Given this list of marker genes VCP, TREM2, CHMP2B, GRN, PSEN1, TMEM106B, MAPT, here is a description of the gene set: species: Homo sapiens An acquired type of sensory aphasia where damage to the brain leads to the loss of the ability to read. Alexia Human Gene Set: HP_ALEXIA